The following is a description of a gene set: Mouse Gene Set: GOBP_SENSORY_PERCEPTION_OF_PAIN The series of events required for an organism to receive a painful stimulus, convert it to a molecular signal, and recognize and characterize the signal. A painful stimulus is any physical or chemical event that has the potential to cause tissue damage (actual or perceived) and activates the nociceptive system. studied in species Mus musculus, and this is the list of marker genes: Nrg1, Pnoc, Tmem120a, Oprl1, Npy1r, Gip, Nmu, Tac1, Hoxd1, Prdm12, Ccl2, Ngf, F2r, Comt, Pomk (NCBI Gene Id 74653), Smr2, Spx (spexin hormone), Grm1, Grm8, P2rx7 (NCBI Gene Id 18439), Rnf170, Arrb2, Fabp5, Scn1a, Mgll, Dlg2, Il18, Tmem100, Mapk1, Ccr2, Zfhx2, Fyn, Grin2b, Trpa1, Ano1, Grin2a, Itga2, Htr2a, Nr2f6, Fto, Mapk3, Scrn3, Gpr171, Retreg1, Kcna2, Calca, Trpv1, Scn9a, Disc1, Phf24, Mme (membrane metallo endopeptidase), Kcnip3, Kcnk4, Mmp24, Smr3a, Grin2d (NCBI Gene Id 14814), Pawr, Aloxe3, Mecp2, Smr2l (NCBI Gene Id 674261), P2rx4, Pirt, Htr7, Adora1, Iapp, Oprk1, Atpsckmt, Nmur2 (neuromedin U receptor 2), Aqp1, Chrna4, Ndn, Asic3, Grin1, Hoxb8, Cdk5, Prx, Tafa4, Kcnd2, Nlgn2, Ntsr1, Kcna1, Tlr4, Cxcr4, Cacna1e, Scn10a, Ccn3, Oprm1, Nipsnap1, Ntrk1, Cxcl12, Mc1r, Cacnb3, Ephb1, Scn11a, Bace1, Acp3, Ccl3, Lxn, Grm3, Penk, Ptges, Abcb1a, Tac4, Chrna5, Chrnb2, Tnf